Given this list of marker genes AMER1, CSNK1A1, PPP2R1A, PPP2CA, PPP2R5E, PPP2R5D, GSK3B, AXIN1, PPP2R5C, PPP2R5B, PPP2R1B, APC, PPP2R5A, CTNNB1, PPP2CB, here is a description of the gene set: part of: Signaling by CTNNB1 phospho-site mutants Reactome Pathway: CTNNB1 T41 mutants aren't phosphorylated T41 mutations of beta-catenin interfere with GSK3 phosphorylation and result in stabilization and nuclear accumulation of the protein. T41 mutations have been identified in cancers of the liver and brain, as well as in the pituitary, endometrium, large intestine and skin, among others. studied in species Homo sapiens